The following is a description of a gene set: Mouse Gene Set: GOBP_SNORNA_LOCALIZATION Any process in which small nucleolar RNA is transported to, or maintained in, a specific location. studied in species Mus musculus, and this is the list of marker genes: Fbl, Znhit3 (NCBI Gene Id 448850), Nop58, Pih1d1, Znhit6